Given this list of marker genes MYB, F11R, POU4F2, CLCF1, FN1, PARP6, CTNNB1, PBRM1, RIPK2, ANAPC2 (anaphase promoting complex subunit 2), DHX36, NTRK3, TMEM64, IL21, HLA-DRB1, RGS14, TREM2, NTRK2, STAT5B, HCLS1, GPER1, IL2RG (interleukin 2 receptor subunit gamma), BDNF, ANXA1, AMIGO1, LTA, IL4I1, MAP6, MIR221, SERPINF1, HLX (H2.0 like homeobox), TM4SF19, EP300, MAP3K13, IFNG, MME, ROBO1, AURKA, PRKDC, KHDC3L, SMAD7, MYF5, SLITRK1, SMO, PTPRC, KITLG, TNFSF9, IL1B, PPARGC1B, SART1, MAPT, CD86, SEMA4D, WNT10B, FBXW8, NTN1, GAS6, PLXNC1, GATA3, MIR125B1, BAIAP2, SEMA7A, GOLGA4, RASGRP1, IL1RAPL1, QKI, IL1RL2, MIR486-1, NKX6-1, NKAP, CDKL3, FGF2, CHODL, TTBK1, LCK, SMARCD2, CD83, NEURL1, BRAF, PF4, HES1, DMRTA2 (NCBI Gene Id 63950), IHH, PLXNB2, CCR1, PRKCH, IL10, VEGFC, TRAK1, MAP1B, AP3D1, FOXG1, CDON, ELL3, SYK, ADIPOQ, SASH3, EPHA4, WNT3A, MIR145, ACTN3, MAG, PDE3A, METRN, ZBTB16, FXR1, NFKBID, NAP1L1, CUX2, ZFYVE27, MYRF, BRD4, SLIT2, TESC, FOXP3, IL7R, CD101, ARID1A, AMBRA1, GFAP, TIAM2, BCL6, GPR68, TNFRSF11A, MYOG, SOX4, CDH5, NOTCH2, HLA-G (NCBI Gene Id 3135), CR1, CALCA, ADD1, EFNA5, OPA1, AP3B1 (NCBI Gene Id 8546), AGER, DCT, PTN, SPEN, SHTN1, SPINT1, RHOA, HMGB1, RHEB, ZMIZ1, ACTL6B, SHOX2, TRAF6, CX3CL1, CTNNBIP1, OTP (NCBI Gene Id 23440), RELA, OCSTAMP, ADAM7, MACF1, HDAC2, IST1, ZAP70, WNT3, TNFSF4, POU4F1, NR2E1, IL12RB1, ARID1B, LYN, XRCC5, HLA-DRA, ITGB1, MMP14, LGALS1, CASP8, ROBO2, ZBTB7B, BRD7, ACTB, TBC1D24, ID2, ISLR2, IL18, FMR1, SOX10, STAT5A (signal transducer and activator of transcription 5A), LGALS3, PPP3CA, MYOD1, CAMK2B, ASCL1, OPRM1, KLHL25, SOX8 (SRY-box transcription factor 8), NKX2-2, IL34, MPL, SNW1, BCL2, LPAR3, LIF, RFX3, CLCN2, PRMT5, MYF6, TENM4, TGFBR2, CD4, PLXNB3, EEF2K, PTPRD, SS18L1 (SS18L1 subunit of BAF chromatin remodeling complex), PHF10, EPHB2, PRKCZ, CBFB, LILRB2, CXCR4, RUFY3, IL15, SLC7A5, TGFB1, VEGFA, XRCC2, TNFRSF12A, FZD3, FZD4 (frizzled class receptor 4), TRPV2, CYLD, BIN1, RAG1, TNFRSF1B, SHH, GPRASP3, EEIG1, NRDC, TSPO, DUSP10, HSF1, TMPRSS12, CLDN5, NPTN, MTOR, IL7, DICER1, DCSTAMP, TWF2, TOX, CDKL5, BRD2, STK11, ZNF488, FOXO3, CAPRIN2, SMURF1, VNN1, STK25, HAP1, HAX1, MEGF8, NRP1, LEF1, RIPK1, IL20, PCID2, MAN2A1, WNT2, CLEC7A, MAP2K2, CD46, IL6ST, SHANK3, RPTOR, PLXND1, MIR222, RNF112, ADA (adenosine deaminase), IL17A, HIF1A (hypoxia inducible factor 1 subunit alpha), SLC9B2, PAX6, SRRT, ZBTB46, MDK, SOCS1, S1PR2, CD27, PLA2G3, RND2, NUMBL, LMOD3, CREB1, CXCL12, CD80, RB1, SHB, ABCB1, SEMA5A, BMPR2, LRP8, TNF, INPP5D, HOXA11, CDH4, PIK3R6, HDAC1, OBSL1, TGM2, MIR142 (NCBI Gene Id 406934), CSF1, VSIR (V-set immunoregulatory receptor), SLC30A1, KLF10, LIG4, ITPKB, NCKAP1L, DBN1, IL36B, AXL, BTN2A2, NEDD9, PNP, IL12B, XRCC6, RUNX3 (NCBI Gene Id 864), SMARCC1, SKIL (NCBI Gene Id 6498), E2F1, IL4R, IL23R, NLRP3, SIRT2, RARA, ASPM, PPP1CC, NKX6-2, CCL19, CD74, SPI1, LILRB4, DDRGK1, ADCY10, UFL1, NUMB, ARID2, PAK1, DISC1, ADNP, ADAM8, ANKRD27, SOX12, EGR3, TLR9, MECP2, GDI1, GLI3, SMARCD1, FES, TRPC5, PCK1, RELN, SMARCC2, TYROBP, RHOH, PLXNB1, NEFL, GPR65, LGALS9, CUX1, BTK, KAT5, IL2RA, LRP2, PLAG1, CRABP2, TESPA1, EVI2B, L1CAM, NIN, IL2, ACTL6A, OLIG2, MIR21, SRF, SOX11, GSX2, KIT, PTPRZ1, SMARCA2, DAG1, NOTCH1, RUNX1, IL23A, SMARCD3, SOCS5, FOS, ETV5, SMARCA4, ZFP36L1, IL6, EGR2, ID4, CAPRIN1, CUL7, GLI2, BMP2, ARMCX5-GPRASP2, XBP1, DRD2, ACIN1 (NCBI Gene Id 22985), TRIB1, LIMK1, BCL11A, HDAC6, IL5, TP73, PRKCA, KRAS, SMARCB1, MAP2K1, SMARCE1, CX3CR1, TNFSF11, STAU2, BAD, TRIM32, ITPKA, IL4, SOX13, FADD, NFKBIZ, KDM1A, PROC, ATXN1, WDR62, SERPINE2 (NCBI Gene Id 5270), ZNF365, FXR2, IL15RA, NGF, GRM5, PPP2R3C, ZNF335, TIAM1, PRKCI, DSCAM, RAB21, PAFAH1B1, BNC1, ZEB2, MALT1, BMP4, RASSF10, ZBTB1, here is a description of the gene set: Human Gene Set: GOBP_POSITIVE_REGULATION_OF_CELL_DEVELOPMENT Any process that increases the rate, frequency or extent of the progression of the cell over time, from its formation to the mature structure. Cell development does not include the steps involved in committing a cell to a specific fate. studied in species Homo sapiens